Given this list of marker genes NAP1L4, PRKRIP1, ZCRB1, CCND1, BCAP31, FEZ2, RHCG, GPKOW, MACROH2A1, SMURF1, SMCHD1, CAB39L, LIF, TMEM39A, NDUFS4, PRKAB2, UBE2Z, MIR142, CCDC138 (coiled-coil domain containing 138), P2RY14, RANBP2, ABCA1 (NCBI Gene Id 8371), AIFM1, TXNRD1, TRIM34, TSPAN33, DNMT1, PHLPP2, DERL3, ZBTB7A, ALCAM, LRCH1 (leucine rich repeats and calponin homology domain containing 1), ADM, ALKBH6, RAMP3, FAP, BEST1, DBNL, ITGA4, LUC7L3, MOCS1, ODC1, HNRNPH2, USP12, COPS4, ACVR1, ARFGAP3, TOP1, BCO2, ACAP2, CD70, CTSK, IL33, PSMD13, VCAN, SH3BP4, FGF23, TCF4, TBC1D2B, PLK4, ASF1A (anti-silencing function 1A histone chaperone), CDO1, SCO1, ST3GAL3, DDHD1, TCEA1, OPLAH, GGTA1, CCL2, MIRLET7E, ITGB8, TMEM67, LRRK2, HMGXB4, APOF, RILPL1, DEDD, SMCO4, HMOX1, TET1, CD34, FAS (Fas cell surface death receptor), GFI1, KPNA1, USP37, FBXO7, SURF4, CHMP2A, PDE4D, IER5, GOLPH3L, DYNC1I2, KLC2, FAH, SLF1, CHSY3, TCAF1, TLR6, JAZF1, TRIP11, PLCL2, USP15, UTP11, FLRT3, FIBP, RABGAP1L, ELMOD2, CENPJ, INSL6, DTNBP1, ADPRH, IL7R, CCNL1, KAT5, STARD3, NLRP3, CALHM6 (calcium homeostasis modulator family member 6), NR1H3, EEF1AKMT2, GTPBP4, SYT17, MBNL2, EMD, LCP1, BTRC, MTF2, SEC23B, WDFY1, CNN3, BLM, MAPKAPK2, DNASE1L3, MORC3, NONO, ETNK2, SGTB, ACSL4, POLDIP3, RAB1A, AHI1, TMEM38B, ZBTB12, LXN (NCBI Gene Id 56925), NAGA, RDH12, PGAM1, HOOK1, SIRT1, RHOC (ras homolog family member C), CPM, DNAJB1, MDM2, LDHD, PDE6D, CRYBG1, MIR10A, PARP3 (poly(ADP-ribose) polymerase family member 3), IL18, APP, PGF, NPHP1, GNS, NOD1, RNF214 (NCBI Gene Id 257160), PPP1R15B, SCARF1, SPECC1L, CD82, MIR450B, GSTM1, IL4, ADAM17, AMY1A, here is a description of the gene set: Human Gene Set: GSE6674_UNSTIM_VS_PL2_3_STIM_BCELL_DN species: Homo sapiens from publication Busconi L, Bauer JW, Tumang JR, Laws A, Perkins-Mesires K, Tabor AS, Lau C, Corley RB, Rothstein TL, Lund FE, Behrens TW, Marshak-Rothstein A (PMID 18025183) We have previously shown that rheumatoid factors (RF) produced by Fas-deficient autoimmune-prone mice typically bind autologous IgG2a with remarkably low affinity. Nevertheless, B cells representative of this RF population proliferate vigorously in response IgG2a/chromatin immune complexes through a mechanism dependent on the sequential engagement of the BCR and Toll-like receptor 9 (TLR9). To more precisely address the role of both receptors in this response, we analyzed the signaling pathways activated in AM14 B cells stimulated with these complexes. We found that the BCR not only serves to direct the chromatin complex to an internal compartment where it can engage TLR9 but also transmits a suboptimal signal that in combination with the signals emanating from TLR9 leads to NF-kappa-B activation and proliferation. Importantly, engagement of both receptors leads to the upregulation of a group of gene products, not induced by the BCR or TLR9 alone, that include IL-2. These data indicate that autoreactive B cells, stimulated by a combination of BCR and TLR9 ligands, acquire functional properties that may contribute to the activation of additional cells involved in the autoimmune disease process. Genes down-regulated in B lymphocytes: control versus PL2-3 (Chromatin IC).